The following is a description of a gene set: Any process that contributes to the maintenance of proper telomeric length and structure by affecting and monitoring the activity of telomeric proteins and lengthening the telomeric DNA. Human Gene Set: GOBP_TELOMERE_MAINTENANCE_VIA_TELOMERE_LENGTHENING species: Homo sapiens, and this is the list of marker genes: SMG6, TNKS (tankyrase), NAT10, ZSCAN4, CCT4, DKC1, XRCC5, RPA1, WRAP53, TERC, PINX1, CCT8, DCP2, TERF2, FBXO4, HNRNPA2B1, XRN1, HNRNPD, PARP3, ACD, HSP90AA1, SLX1A, HNRNPC, CCT2, CCT3, TNKS1BP1, EXOSC10, HNRNPU, HNRNPA1, NAF1, CTC1, CCT6A, RFC1, SLX1B, PIF1, CTNNB1, TNKS2, TP53, TERT, SMG5 (SMG5 nonsense mediated mRNA decay factor), TEN1, TENT4B, STN1, ERCC4, TERF1, TINF2, HMBOX1, HSP90AB1 (heat shock protein 90 alpha family class B member 1), CCT5, MCRS1, RAD51, ATM, NOP10, CCT7, GAR1, ZBTB48, RTEL1, ATR, SLX4, TCP1, PARN, TERF2IP, POT1, PTGES3, DCLRE1B, NHP2, RAD50, PML, DHX36, GNL3L, MRE11, PARP1